The following is a description of a gene set: studied in species Homo sapiens Human Gene Set: GOMF_CYSTEINE_TYPE_DEUBIQUITINASE_ACTIVITY An thiol-dependent isopeptidase activity that cleaves ubiquitin from a target protein to which it is conjugated., and this is the list of marker genes: BAP1, DESI2, USP17L19, UCHL3, USP9Y, USP46, CYLD, USP17L17, USP18, OTUD4, USP17L18, YOD1, OTUD6A, USP24 (ubiquitin specific peptidase 24, NCBI Gene Id 388634), USP6, USP4, OTULIN (NCBI Gene Id 90268), MINDY3, USP17L15, USP43, USP27X, USP17L7, MINDY4B, USP9X, USP34, USP17L21, JOSD2, USP28, USP49, OTUD7B, SENP3, USP37, USP50, USP12, EIF3F, USP7, MINDY4, USP17L24, USP30, ZC3H12A, USP17L11, UFD1, USP45 (NCBI Gene Id 85015), USP17L4, MINDY1 (NCBI Gene Id 55793), USP17L13, USP47, USP15, USP38, USP26, MINDY2, USP1, OTUD1, UCHL5, USP42, USP17L20 (ubiquitin specific peptidase 17 like family member 20), USP8, ZRANB1, USP17L3, USP20, USP17L6P, USP53, USP17L1 (ubiquitin specific peptidase 17 like family member 1), USP17L8, ZUP1, USP19, OTUD3, OTUB1, JOSD1, UCHL1, OTUD5 (NCBI Gene Id 55593), OTUB2, USP14, USP17L23, USP10, USP5, OTUD7A, USP11, USP22, VCPIP1, USP21, USP31 (ubiquitin specific peptidase 31), ATXN3L, USP3, USP51, USP32, ATXN3, USP25, USP17L2, USP2, USP36, USP13, BRCC3, USP39, TANK, USP17L22, USP33, PAN2, USP29, OTUD6B, USP17L5, USP48, USP40, USP35, USP54, USP16, USP44, USP17L10, USP17L12, ALG13, TNFAIP3